The following is a description of a gene set: Human Gene Set: GOCC_CARDIAC_MYOFIBRIL studied in species Homo sapiens A cardiac myofibril is a myofibril specific to cardiac muscle cells., and this is the list of marker genes: MYL2, MYBPC3, TNNT2, MYH7B (myosin heavy chain 7B), CRYAB, TNNI3, DES